Given this list of marker genes NTRK2, LIPG, VSTM4, ZNF544, ERBB4, NR3C2, ZNF704, RORA, ENPP5, TMEM245, DLG3, LMO3, RBPMS, PLPP3, SH3BGRL2, PCSK2, PHEX, FGFRL1, FRMD3, IKZF2, here is a description of the gene set: species: Homo sapiens Anaplastic thyroid carcinoma (ATC) is the most fatal and rapidly evolving endocrine malignancy invading the head and neck region and accounts for up to 50% of thyroid cancer-associated deaths. Deregulation of the microRNA (miRNA) expression promotes thyroid carcinoma progression by modulating the reorganization of the ATC transcriptome. Here, we applied comparative miRNA-mRNA sequencing on a cohort of 28 thyroid carcinomas to unravel the association of deregulated miRNA and mRNA expression. This identified 85 miRNAs significantly deregulated in ATC. By establishing a new analysis pipeline, we unraveled 85 prime miRNA-mRNA interactions supporting the downregulation of candidate tumor suppressors and the upregulation of bona fide oncogenes such as survivin (BIRC5) in ATC. This miRNA-dependent reprogramming of the ATC transcriptome provided an mRNA signature comprising genes sharply distinguishing ATC from other thyroid carcinomas. The validation of the deregulated protein expression in an independent thyroid carcinoma cohort demonstrates that miRNA-dependent oncogenes comprised in this signature, the transferrin receptor TFRC (CD71) and the E3-ubiquitin ligase DTL, are sharply upregulated in ATC. This upregulation is sufficient to distinguish ATC even from poorly differentiated thyroid carcinomas (PDTC). In sum, these findings provide new diagnostic tools and a robust resource to explore the key miRNA-mRNA regulation underlying the progression of thyroid carcinoma. Genes down-regulated in anaplastic thyroid carcinoma and sharply distinguishing ATC from other thyroid carcinomas. from publication Misiak D, Bauer M, Lange J, Haase J, Braun J, Lorenz K, Wickenhauser C, Hüttelmaier S (PMID 34885022) Human Gene Set: MISIAK_ANAPLASTIC_THYROID_CARCINOMA_DN